Given this list of marker genes PTPN2, SIGIRR, YTHDF2, HLA-B, HLA-E, ACOD1, AHR, MICA, DDX39A, DEFB114 (defensin beta 114), NR1H2, SUSD4, PVR, EIF4E2, INPP5D, TRAFD1, NLRC5, USP18, MIR181B1, NECTIN4, IRAK3 (NCBI Gene Id 11213), YTHDF3, SERPINB4 (NCBI Gene Id 6318), NT5C2, LILRA2, ARG1, FOXP3, DEFB118, USP38, VSIG4, TYRO3, DCST1, SPINK5, BANF1, GRB2, NLRC3 (NLR family CARD domain containing 3), SFN, IL4I1, PARP14, IFI16 (NCBI Gene Id 3428), USP5, DNAJA3, GRN, LACRT, CD96, ISG15, KLRD1, PCBP2, ARG2, DTX4, NECTIN2, OAS1, TNFAIP3, OAS3, ATG12, AURKB, ARRB2, HLA-F, STAT2, KLRC1, CARD16, YWHAZ, TTLL12, SLAMF8, OTOP1, MAPKBP1, LYAR, TRIM21, PRDX2, TRIM38, FGL2, KIR2DL4, PPARG, NLRX1, MIR21, ATG5, ZDHHC18, HLA-G, NLRP4, PARP1, MIR4691, IRGM, CNOT7, INS, SMIM30, DRD2, LGALS9, TRAF3IP1, CARD8 (NCBI Gene Id 22900), LTF, RNF26, DHX58, MICB, CEP63, CD274, RPS19, A2M, TRIB1, MAPK3 (NCBI Gene Id 5595), PDCD1, CLEC12B, C1QBP, FAM3A (FAM3 metabolism regulating signaling molecule A), METTL3, TGFB1 (transforming growth factor beta 1), MMP12, UFL1, USP15, PPM1B, CRK, TREX1, HLA-A, SERPINB9, CEACAM1, GIGYF2, NMI, ADAR, LILRB1, MIR26B, NFKBIL1, ILRUN (inflammation and lipid regulator with UBA-like and NBR1-like domains), CR1, HAVCR2, TIGIT, CACTIN, SAMHD1, SIRPA, SERPING1, MUL1, NR1H3, DUSP10, TARBP2, PIM1, ITCH, PTPN6 (NCBI Gene Id 5777), here is a description of the gene set: Human Gene Set: GOBP_NEGATIVE_REGULATION_OF_RESPONSE_TO_BIOTIC_STIMULUS Any process that stops, prevents, or reduces the frequency, rate, or extent of a response to biotic stimulus. species: Homo sapiens